Given this list of marker genes CACNA2D2 (calcium voltage-gated channel auxiliary subunit alpha2delta 2), ADRA2A, GNG3, GNG4, GNB1, CACNA1C, GNG13, GNG10, GNG8, GNB3, ADCY6, ADCY5, GNB2, GNG12, GNG7, ADRA2C, GNG5, GNGT1, CACNB2, GNB5, GNG2, GNGT2, GNAI1, CACNB3, GNB4, GNAI2 (NCBI Gene Id 2771), CACNA1D, GNG11, here is a description of the gene set: Adrenaline,noradrenaline inhibits insulin secretion Human Gene Set: REACTOME_ADRENALINE_NORADRENALINE_INHIBITS_INSULIN_SECRETION species: Homo sapiens